Given this list of marker genes Slc35c2, Fut11, Pofut2, Fut10, B3glct, Pofut1, here is a description of the gene set: studied in species Mus musculus Mouse Gene Set: GOBP_PROTEIN_O_LINKED_FUCOSYLATION The process of transferring a fucosyl group to a serine or threonine residues in a protein acceptor molecule, to form an O-linked protein-sugar linkage.